The following is a description of a gene set: Any process that activates, maintains or increases the frequency, rate or extent of the directed movement of amines into, out of or within a cell, or between cells, by means of some agent such as a transporter or pore. species: Mus musculus Mouse Gene Set: GOBP_POSITIVE_REGULATION_OF_AMINE_TRANSPORT, and this is the list of marker genes: Kmo (NCBI Gene Id 98256), Gabbr1, Psen1 (presenilin 1), Plcd1, Adora2a, Slc36a2, Htr6, Oxtr, Avp, Stxbp1, Itgb1, Agt, Ntsr1, Syt1, Cck, Slc38a1, Slc6a1, Htr2c, Syt4, Rab3b, Drd2, Grk2, Oprk1, Rtn4, Slc38a3, Abat, Rab3gap1, Cartpt, Avpr1a, Oxt, Stx1a, P2rx7, Slc12a2, Chrnb2, Dpysl2, Adora2b, Nr3c1, Pink1, Pcp4, Kcnb1, Slc17a8, Tacr2, Trh, Slc18a1, Ace2, Slc7a5, Arhgef11, Npy2r, Grin2b, Nat8l, Slc18a3, Grik1, Cxcl12, Dtnbp1, Arl6ip1, Cltrn